The following is a description of a gene set: species: Homo sapiens The chemical reactions and pathways resulting in the formation of collagen, any of a group of fibrous proteins of very high tensile strength that form the main component of connective tissue in animals. Collagen is highly enriched in glycine (some regions are 33% glycine) and proline, occurring predominantly as 3-hydroxyproline (about 20%). Human Gene Set: GOBP_COLLAGEN_BIOSYNTHETIC_PROCESS, and this is the list of marker genes: RUNX1, TMEM131, IHH, MIR29A, SUCO, MIR149, TGFB3, CYP7A1, RGCC, MYB, IL6, IL6R, SERPINF2, ITGA2, EMILIN1, PRDX5, VIM, LARP6, MIR145, F2, PCOLCE, INHBA, CIITA, SERPINH1, CREB3L1, UCN, AMELX, RAP1A, CYGB, RCN3, SERPINB7, MIR218-1, GOT1, PPARD, DDR2, MIR29B1, TGFB1, BMP4, COL5A1, SCX, FOSL2, ADAMTS3, ERRFI1, NPPC, F2R, TRAPPC8, CBX8, NOTCH1, P3H4, TRAM2 (NCBI Gene Id 9697), MIR92A1, COL1A1, P3H3, WNT4